The following is a description of a gene set: studied in species Homo sapiens Binding to the microtubule constituent protein alpha-tubulin. Human Gene Set: GOMF_ALPHA_TUBULIN_BINDING, and this is the list of marker genes: DIP2B, TBCB, B4GALT1, SNCA, ARL8B, TBCE, TRPV4, WIPF3, ARL8A, WASHC1, EML4, DNAL1, FAM110C, CAV3, TTLL7, NCALD, NDEL1, TAOK1, SETD2, HSPH1, SLC6A2, HDAC6, PACRG, ARL4C (ADP ribosylation factor like GTPase 4C), BEX4, ENKD1, GJA1, FYN, BBS4, OFD1 (OFD1 centriole and centriolar satellite protein), FNTA, TBCEL, DLEC1 (DLEC1 cilia and flagella associated protein), LRRC61, EFHC1, TRIM36, RACGAP1, INO80, WASH3P, SPMIP6, SPAST, TRAPPC14 (trafficking protein particle complex subunit 14), CDK5R1, WASH6P